Given this list of marker genes AVPR1A, AVP, AVPR1B, here is a description of the gene set: Arginine vasopressin (AVP(20-28)) is a 9 amino-acid long signal peptide produced by cleavage of the precursor protein AVP in the hypothalamus. It mediates the reabsorption of water in the kidney and its synthesis and release are physiologically regulated by plasma osmolarity, blood pressure and/or blood volume. AVP(20-28) binds to vasopressin receptors AVPR1 and 2, located on the basolateral surface of the kidney collecting duct. This binding results in interaction of AVPRs with the G protein alpha-s. Following a cascade of downstream events, ultimately the water channel aquaporin 2 (AQP2) translocates from intracellular stores to the apical surface where it functions as the entry site for water reabsorption. When water balance is achieved, plasma levels of AVP(20-28) drop and AQP2 levels in the apical plasma membrane are decreased.<br><br>Mutations in AVP make it unavailable to its AVPRs in the kidney, resulting in dysregulation of water reabsorption. This can cause familial neurohypophyseal diabetes insipidus (FNDI), an autosomal dominant disorder characterised by persistent excessive thirst resulting in constant drinking (polydipsia) and passage of large volumes of urine (polyuria). In FNDI, the production and release of AVP from the posterior pituitary gland is impaired. studied in species Homo sapiens Reactome Pathway: Defective AVP does not bind AVPR1A,B and causes neurohypophyseal diabetes insipidus (NDI) part of: SLC transporter disorders